Given this list of marker genes Tnrc18, Cdh8, Lrrtm3, Traf6, Sipa1l1, Eps15 (NCBI Gene Id 73669), Pcbp4, Zfp281, Fubp1, Galr1, Vamp2, Rbms3, Hnf1b, Yae1d1 (Yae1 domain containing 1), Pdhx, Ptpn3, Ppp1r9b, Ntng1, Gss, Iqsec2, Calr3, Slc17a4, Exoc6b, Isl1, Wdtc1, Eif5a, Afap1, Zmym3, Usp1 (NCBI Gene Id 230484), Cask, Dgki, Cx3cl1, Igfbp3, Mib2, Tspan6, Zfp512b, Dnajc10, Trib2, Gid8, Cyp2b19, Loxl2, here is a description of the gene set: Mouse Gene Set: MIR_3076_5P species: Mus musculus Genes predicted to be targets of miRBase v22 microRNA mmu_miR_3076_5p in miRDB v6.0 with MirTarget v4 prediction scores > 80 (high confidence targets). from publication Chen Y, Wang X (PMID 31504780)